The following is a description of a gene set: Gliosis studied in species Homo sapiens Human Gene Set: HP_GLIOSIS Gliosis is the focal proliferation of glial cells in the central nervous system., and this is the list of marker genes: CSF1R, EHMT1, MOCS1, AKT3, NR4A2, ATXN2, PRNP, FBXO7, NAXD (NCBI Gene Id 95526), TARDBP, ESAM (NCBI Gene Id 90952), CNTN2 (contactin 2), VPS35, ATXN8OS, CYP27A1, TLR3, VRK1, KDM3B, PSEN1, COX15, SNCAIP (synuclein alpha interacting protein), NDUFS8, ARX, ADNP, ATXN3, BRAT1, ETFDH, GRN, KCNT1, POLG, MTOR (NCBI Gene Id 2476), TBCD, PIK3CA, ATP6V1A, AP4M1, SLC25A46, UBQLN2, C9orf72, PLA2G6, MT-ATP6, ZNF335, SCO2, HTT, TYROBP, TBK1, LONP1, PDHA1, MOCS2, DNAJC13, FUS, ADH1C, AVP, PAX2, GIGYF2, GLS, BCS1L, NGLY1, DTYMK, SQSTM1, LRRK2, LRPPRC, PIGA, ETFA, COQ4, KMT2C, MAN2B1, L2HGDH, PLP1, HSD17B4, PMPCA, ERCC6, KARS1, SERPINI1, YY1, ADAR, ETFB, EIF4A2, SNCA, GDAP2, RANBP2, RNU4-2, MT-TT, VCP, DYRK1A, TFG, EIF4G1 (eukaryotic translation initiation factor 4 gamma 1), THOC2, ABCB7, PRKN, NARS2, NUP62, TSEN54, FARS2, TBP, MAPT, EIF2B1, NUP54, GBA1, CHCHD10 (NCBI Gene Id 400916), TEFM